Given this list of marker genes FOXA2 (forkhead box A2), CTNNB1, NOTO, SMAD3, SMAD2, TBXT (NCBI Gene Id 6862), YAP1, TCF7, FOXA1, FOXH1, SHH, LEF1, TEAD4, TEAD2, here is a description of the gene set: Human Gene Set: REACTOME_FORMATION_OF_AXIAL_MESODERM species: Homo sapiens Formation of axial mesoderm